The following is a description of a gene set: Human Gene Set: GOCC_AXON studied in species Homo sapiens The long process of a neuron that conducts nerve impulses, usually away from the cell body to the terminals and varicosities, which are sites of storage and release of neurotransmitter., and this is the list of marker genes: MAPK8, CNTN1, DOCK7, CRYAB, CDH8, C1QL1, NMNAT2, TULP1, SYN1, NRCAM, LRP8, KCNA4, HSP90AA1, SLC17A8, LAMP5, KIF20B, NECTIN1, TRPC5, RAB5A, MUL1, OPHN1, TOR1A, ADAM21, NTRK3, ABI1, SLC32A1, DYRK1A, GAD1 (glutamate decarboxylase 1), OPRM1, PTBP2, BASP1, GHRH, PDYN, BORCS5, KIF5B, GHRL, OPRD1, NTRK1, CCDC120, BCAR1, RTN4RL2, MYH14, FSCN1 (NCBI Gene Id 6624), LRRK2, C4B, BCR, PRKCB, ABITRAM, MYH10, ENO2, CTTN, KCNA6, ACTL8, TNN, CNTF, OLFM1, ALDH1A1, GRM3, SLC1A1, PACSIN1, SNAP25 (NCBI Gene Id 6616), CALB1, PREX1, TPGS1, NRP2, PSEN1, TMEM151A, DTNA, ADGRL1, MACO1, TGFB2, MAP2K1, BLOC1S4, UHMK1, KCNH1, CPLX4, SPTA1, TANC2, UCHL1, PRKCZ, GNRH1 (NCBI Gene Id 2796), SLC8A3, MINK1, SLC18A3, SLC5A7, FSCN3, NCMAP, SYT5, LDLRAP1, KIF1A, APBB1, SCN9A (sodium voltage-gated channel alpha subunit 9), DGKI, HCN1, AP3D1, ACTG1, GRIPAP1, SLC18A1, SYT8, SMURF1, BACE1, SEPTIN8, EVX1, HDAC6, GABRA2, CRTAC1, SCN1B, CTNNA2, CPT1C, TRAK1, PPP1R9B, KCNQ2, GRM7, KIF13B (kinesin family member 13B), ROBO4, EEA1, ELFN1, GARS1, ARPC3, WHRN, ARHGAP4, LRRC7, NECAB2, ACTBL2, INPP5J, SLC12A6, NTRK2, ATCAY, PARK7, NRSN1, OXT, ADAM10, EXOC7, MAG, EXOC6, STX1A, NRN1L, GRIK3, CCK, RANGAP1, AP3B1, SCN10A, ATG16L1, DPYSL3, ATL1, LRRC4B, ELAVL4, ACTB, RET, NRP1, BSN, SYT1, SLC17A7, PRPH, VSTM5, BLOC1S5, RAB3A, BAG2, SPAST, SYT11, DRD2, SSNA1, HAPLN2, AGTPBP1, MYO9A, SYT4, SCGN, KATNB1, SLC4A8, STAT1, STX3, ARL8A, KIF3A, BLOC1S6, AP3B2, SLC4A10, AMIGO1, FLRT3, FAM168B, ATP1A1, USP9X, SNCA, PTPRO, HMCN2, LLGL1, CNR1, KCNQ3, ITGA4, RAP1GAP, MYPN, CYTH2, CRH, CYP17A1, IRX3, AUTS2, NEFH, MAP7, RAB21, HSP90AB1 (heat shock protein 90 alpha family class B member 1), BLOC1S3 (NCBI Gene Id 388552), POTEE, CACNG7, CNTN5, ATP1A3, IGF1R, MDGA1, OPA1, ANG, RNF6, GRIA1, TRPV4, MTMR2, KCNAB2, POTEKP, PRNP (NCBI Gene Id 96713), FRMD7, CREB1, SYT7, IGF2BP1, CDK5, GDPD5, PTCH1, DAB2IP, PRRT2, ROGDI (rogdi atypical leucine zipper), SLC18A2, LMTK2, KCNK2, CABP4, TAC1, SETX, TWF2, LGI3, GAD2, KIF5A, FXR1, L1CAM (NCBI Gene Id 4268), SCN1A, ADCY9, CDKL5, GABBR1, ATG5, PNOC, SEMA3A, MYOC, KLC1, NGF, SIRT2, DHX36, ARMCX3, SLC38A1, SRSF10, DISC1, SLC8A1, CADM2, GABRG2, NCDN, MYO1D, HOMER1, UNC80, PRSS12, EPHB1, MYCBP2, APBB2, ANK1 (ankyrin 1), C9orf72, BRSK2, TPBG, CNTN6, STX1B, CBL, UCN, OTX2, EPHB2, CPLX3, KIF21B, SEPTIN4, GPM6A, NGFR, SMN2, CCSAP, ADORA2A, FLNA, VIM, COPG2, MYOT, OPN4, MME, TUBB4A (NCBI Gene Id 1864), CALCR, HSBP1 (heat shock factor binding protein 1), NTF4, SYAP1, ITGA3, TRPA1, PPT1, ADAM11, CACNG2 (calcium voltage-gated channel auxiliary subunit gamma 2), MAP1A, NECTIN3, ANK3, NIN, NTNG2 (netrin G2), ZNF804A, KCNA1 (potassium voltage-gated channel subfamily A member 1), ADGRL3, STAU2, RTN4R, SCN11A, SPTBN1, CPLX1, NPTN, HCN4, NEK3, ATAT1, PALS1, CALM2, POTEI, TPRG1L, LRIG2, FMR1, INPP5F, CDK5R2, ACADM, MAST1, KCNC3, PRKAA2, TGFB1, CALB2, FEZ1, NFASC, HTR2A, TXNRD2, EXOC8, PCDH9, SMN1, IGSF9, ROR2, OMP, BLOC1S2, ROR1, ADRA2A, PRKCG, MAP6, EPS8, PINK1, GABRD, EXOC4, GRIN1, TANC1, CDK5R1, SYNJ1, KCNAB1, CNTN4, PLEC, UNC13A, MAP3K12, CD2AP, ADAM22, DTNBP1, SOD1, TSHZ3, TIAM2 (TIAM Rac1 associated GEF 2), IQCJ-SCHIP1, KCNA3, ALCAM (activated leukocyte cell adhesion molecule), AVIL, PCDHGB1, MAP2, FZD3, SRCIN1, NTSR1 (NCBI Gene Id 4923), NEO1, KIF1C, USH2A, FKBP15, DCTN1, FKBP4, HAP1, CNGA3, CHRNA10, SLC1A2, SYBU, TBC1D24, ALS2, IL31RA (NCBI Gene Id 386652), DST, CNGB1, PLXND1, CBARP, AP3M2 (NCBI Gene Id 10947), CAD, SPOCK1, SYP, PPFIA2 (PTPRF interacting protein alpha 2), TMEM230, BLOC1S1, CRMP1, KIF5C, ERMN, AP3S1, STXBP1, ATP6V0D1, SEPTIN14, CXADR, ROBO1, KIF1B, NDRG2, PLEKHG5, DCC, SLC6A1, TPX2, UCN3, TRPM1, PTK7, ATP2B3, GOT1 (NCBI Gene Id 2805), NGEF, DIP2B, NMNAT3 (nicotinamide nucleotide adenylyltransferase 3), SARM1, SEPTIN6, DSCAML1, CALM1, HIF1A, DLG4, EPHA5, ADNP, EPHA4, MAPK8IP1, MT3, AQP1 (aquaporin 1 (Colton blood group)), NGDN, AGBL4, SEMA6A, PUM1, ERC2, SPTBN4, FBXW11, TAOK2, CHRM1, RIN3, DBN1, HCN3, TENM2, MYO5A, KCNB1, GLDN, MADD, NAV1, LPAR3 (lysophosphatidic acid receptor 3), CASR, RAC3, CALCA, GSK3B, ATP7A, SACS, ELK1, PVALB, KIF21A, VPS16, ZFYVE27 (zinc finger FYVE-type containing 27), SHANK2, SLC38A7, LGI1, HPCA, MGARP, EMX2, SBF2 (NCBI Gene Id 81846), SLC38A8, WDR47, THY1, TRIM46, NDEL1, ZC3H14, GSK3A, INSRR, MAPK8IP3, HSPB1, FGF13, CLASP2, SNCG, STMN3, NMU, ACAP3, ARL8B, KLHL20, GFRA1, DNM2, CRHBP, GRM2, NF1, NLGN2, SEPTIN11, TSPOAP1, POTEF, DLG1, NEFL, KCNQ5, AAK1, ABL1, TUBB3, MAPT, DAGLA, UNC13C, WDFY3, HTT, NPY, GDI1, TRPV2, NCAM2, CTSZ, SERPINF1, NOS1, SCN2A, DLG2, KCNA2, CORO1A, KCNK4, COMT, PRKAA1, ULK1, ADCY10 (adenylate cyclase 10), SSH1, PALLD, GRIK2, KCNC4, AMFR, NTS, EPB41L3, CRHR2, CPNE6, COBL, POTEJ, CFL1, N4BP3, LRRTM1, BTBD8, ROBO3, IGHMBP2 (immunoglobulin mu DNA binding protein 2), ATOH7, BIN1, SH2D3C (NCBI Gene Id 10044), TENM3, MICAL1, ADCY8, DVL1, LMTK3, CD200, AP3M1, ADORA1, P2RX3, IL1RAPL1, TERF2, CLDN11, CNTNAP1, KLHL24, SYT13, SLC2A13, AZIN2, EMB, DCTN2, KCNC1, NETO1, UNC13B, NCS1, NRGN, CLCN2 (NCBI Gene Id 79179), NEFM, MAP7D2, SYT2, DAG1, TRAK2, MAF1, RASGRF1, CALM3, PENK, TMEM108, NRXN1, KIF4A, CLCN3, RGS7BP, DYNC1H1, SCN2B, NEXN, FZD5, BOC, AURKA, BMPR2, PARD3, LRP2, ZPR1, KIRREL3, KIF3B, SIGMAR1, PALM, TH, GIT1, SLC6A3, STMN4, SNCB, PTPRN, CLDN5, PAK1, PRKN, PTPRS, SPG11, BSG, CNTNAP2, SNAPIN, BRSK1, CPEB4, MAP1B, CNTN2, ABR (ABR activator of RhoGEF and GTPase), NFIB, ATP6AP2, MYC, HCN2, SLC8A2, C4A, FEZ2 (NCBI Gene Id 9637), KCNC2, SPG7, CSNK1E, NPFF, ROBO2, AP3S2, MBP (NCBI Gene Id 4155), BDNF, OPRK1, COPA, PTK2B, MAP4, UNC5C, MAP9, SHTN1, RAB27B, PPFIA1, ITGA2, PCLO, SLC38A2 (NCBI Gene Id 95454), STMN2, CD40, SCN8A, LRFN3, CIB1 (NCBI Gene Id 10519), GAP43, EXOC3, GPRIN1, GPER1, INSR, IQGAP1, SLC30A3 (solute carrier family 30 member 3), CPLX2, DSCAM, PAFAH1B1, DYNLL1, ACTR10, RUFY3, NTF3, APP, AP1S1, SLC6A2